Given this list of marker genes MAPK1, FANCE, POGZ, IARS1, LAMA3, KDM6A, OTUD5, COL18A1, LAMB3 (NCBI Gene Id 3914), SHOC2, FANCD2, KMT2D, FANCA, PIGL, TELO2, FANCC, PIGA, LAMC2, TNXB, TP63, PSMC1, JAG1, DHCR7, here is a description of the gene set: A duplication of the collecting system of the kidney, defined as a kidney with two (instead of, normally, one) pyelocaliceal systems. The pyelocaliceal system is comprised of the renal pelvis and calices. The duplicated renal collecting system can be associated with a single ureter or with double ureters. In the latter case, the two ureters empty separately into the bladder or fuse to form a single ureteral orifice. Duplicated collecting system Human Gene Set: HP_DUPLICATED_COLLECTING_SYSTEM species: Homo sapiens